Given this list of marker genes MTMR7, ABHD16A (abhydrolase domain containing 16A, phospholipase), C1orf52, SAP130, SH2B1, MED17, COMMD9 (NCBI Gene Id 399879), GORASP1, POGZ, NUMA1, TEX261, KMT2A, MORF4L1, PRRC2B, VPS26B, BAZ2A, NUCKS1, TBC1D10B, PRDM4, ASB7, KDM3B, SAMD4B, DHX36, TAF9B, METTL17, SEC22C (NCBI Gene Id 9117), RNF41, TTC17, SAFB, RSC1A1 (regulator of solute carriers 1), CIZ1, MSL1, LEMD3, TMEM245, CRAMP1, TNPO2, TRAPPC14, PRPF8, NF2, SNRNP200, CFAP298, WDR6, ANKRA2, ZNF512, MTMR4, MOB4, THUMPD1, UPF3A, WDR73, SPTLC1, COQ10A, CHD9, SIN3A, RPL7L1, LINC01278, BAHD1, here is a description of the gene set: Neighborhood of NUMA1 nuclear mitotic apparatus protein 1 in the GCM expression compendium Neighborhood of NUMA1 Human Gene Set: GCM_NUMA1 species: Homo sapiens